The following is a description of a gene set: Genes predicted to be targets of miRBase v22 microRNA mmu_miR_494_3p in miRDB v6.0 with MirTarget v4 prediction scores > 80 (high confidence targets). from publication Chen Y, Wang X (PMID 31504780) species: Mus musculus Mouse Gene Set: MIR_494_3P, and this is the list of marker genes: Rbm4b, Gm5148, Lcorl, Map7d2, Chd9, Aurkb, Gtf2f2, Dennd6a, Dpm1, Wdr44, Usp31, Aldh1l2, Pla2g4e, Pten, Slc25a16, Tmem237, Zfp93, Atp2c1, Ccnyl1, Myo6, Prickle2, Fut9, Gm5142, Ankhd1, Lrrcc1, Cadps, Lmbrd1, Rnf152, Lrp2bp, Crhbp, Plekha8, Vwde, Bpnt2, Akap11, Slc26a3, Lmo4, Pcdh10, Pphln1, Ampd2, Mlxip (MLX interacting protein), Lancl3, Tfdp1, Lrfn5, Cggbp1, Arhgap12 (NCBI Gene Id 75415), Mtarc1, Rb1cc1, Poglut2, Stxbp5, Nadk, Klhl2 (NCBI Gene Id 78235), Tenm2, Spink10, Nhsl3, Asxl2, Bcl2a1b, Rbm24, Aff3, Esp3, Scimp, Mpeg1, Stt3b, Bcap29, Galnt3, Mbd5, Dnaja2 (DnaJ heat shock protein family (Hsp40) member A2), Cab39, Clta, Scn2a, Gls, Pabpc4l (poly(A) binding protein, cytoplasmic 4-like), Pter, Zic2, Ccdc136, Enthd1, Rc3h2, Slc4a4, Lig4, Asph, Iqschfp, Cep57l1, Clint1 (NCBI Gene Id 320445), Crh, Dr1, Cdk6 (cyclin dependent kinase 6), Arl6ip1, Dbn1, Pof1b, Arhgap5, Stard3nl, Ranbp6, Prtg, Heph, Tex13b, Stmnd1, Nectin3, Polr3g, Gabra5, Wnk3, Lmo1, Dnajc21, Casp2, Elp1, Dsg2, Dhx40, Cnot6, Dcp1a, Npr3, Szrd1, Brwd3, Htra3, Avl9, Tomm70a, Snrpn, Cftr (cystic fibrosis transmembrane conductance regulator), Rps6ka2, Nr4a3, Nadk2, Sowahc, Ankrd40, Nfib, Rnf138, Col25a1 (collagen, type XXV, alpha 1), Gcc2, Rad23b, Ssh2, Pip4p2, Irak1bp1, Wwc2, Rprd1a, Hapstr1, Ankrd10, Cxxc4, Tbc1d15, Zfp871, Schip1, Jund (NCBI Gene Id 16478), Phf8, Cyp2b23, Atf3, Tmem255a, Srp54c, Pds5b, Sos1, Tnrc6b, Mbnl3, Cks1b, Eda2r, Ier3ip1, Vit, Cntd1, Septin9, Tbc1d8, Slc46a3, Ro60 (NCBI Gene Id 98411), Nfia, Rfx7, Map6, Cbll1, Sema3a (sema domain, immunoglobulin domain (Ig), short basic domain, secreted, (semaphorin) 3A), Unc80, Map2k6, Tmem132b, Dcbld2, Prdm6, Rock1, Hlf, Syne2, Rbm39, Hilpda, Spag16, Nr1d2, Fgfr2, Pou3f2, Osbpl6, Zfp207, Tank, Clock, Sptbn1, Rpgr, Tacc1, Ppp4r3a, Fbxl17, Shoc2, Bcl7a, Rap1b, Dip2c, Ubp1, Cibar1 (NCBI Gene Id 68099), Xk, Zbtb14, Vcpip1, Lclat1, Nsun6, Rundc3b, Phactr2, Myct1 (myc target 1), Mastl, Glis3, Socs5, Lif, Galnt4, Atxn3, Snurf, Csmd3, Clptm1l, Stxbp6, Zranb3, Frs2, Zfx, Phox2b, Slc9a6, Pctp (phosphatidylcholine transfer protein), Mrps14, Trim44 (tripartite motif-containing 44), Zfp963, Prl3b1, Nlrp9a, Shox2, Gli3, Mospd2, Atp10a, Slc22a17, Fam120a, Tlnrd1, Ptpn12, Txndc12, Zfhx3, Fgf7, Syne1, Etv1, Elf2 (NCBI Gene Id 99951), Nova1, Tmem167, Gpr45, Smarca5